Given this list of marker genes PCDHA6, DIS3, PCDHA3, CD300E, ARL6IP6, EPHA3, SAR1A, AGTR2, PCDHAC2, ZNF566, GK5 (glycerol kinase 5), MDM1, ZNF800, NAA50, TENM2, OPN5, INSM2 (INSM transcriptional repressor 2), SOBP, GOLGA7, PCDHAC1, CLIC4, PCDHA1, CD164, PCDHA11, PCDHA12, PCDHA7, ZDBF2, NDN, G2E3, NADK, CCSER2, PCDHA8, EIF3J, POLR1G, PCDHA13, PCDHA4, COL5A2, MYO3A, EPYC, PTCHD3, OAS1, BMPR1B, RPS6KA3, ARCN1, CLVS1, SLC11A2 (NCBI Gene Id 4891), MAP2K1, GRIA4, PIP4P1, ACVR1C, RNF41, GSTM4, ZNF704, ZNF214, TYR, SLC17A7, PCDHA5, P2RY12 (NCBI Gene Id 65213), CADPS, GGACT, TUSC1, ANGPTL3 (NCBI Gene Id 54222), PCDHA10, ADRA1D, CYP27B1, G6PC2, JPH3, OAS2, KIAA0232, CLDN12, SNX9, PCDHA2, PROX1, STAU2, UBXN4, KCNIP2, BEND7, here is a description of the gene set: from publication Chen Y, Wang X (PMID 31504780) Genes predicted to be targets of miRBase v22 microRNA hsa-miR-6824-5p in miRDB v6.0 with MirTarget v4 prediction scores > 80 (high confidence targets). species: Homo sapiens Human Gene Set: MIR6824_5P